The following is a description of a gene set: studied in species Mus musculus Mouse Gene Set: chr8A4, and this is the list of marker genes: Adam34l, Gm38414, Pcm1, Gm5609, Eri1, Gm8436, Zfp148-ps1, Gm45566, Gm2221, Gm35629, Gm26150, Mir6395, Smarce1-ps1, Gm5347 (NCBI Gene Id 384814), Gm34597, Gm5787, Rps12-ps24, Gm26181, Gm16348, Saraf, Gm18414, Gm6180, Gm2080, Erhrt-ps, Prag1, Gm3433, Ccnq-ps4, Triml1, Rpl31-ps23, Adam26b, B930018H19Rik, Gm33968, B430010I23Rik, Gm33831, Sgcz, Gm18644, Trmt9b, Zfp42, Gm9939, Adam34, Gm8423, Gm9951, Gm16193, Gm45349, Gm6284, Slc7a2, Dusp4, Gm34368, 2810404M03Rik, Gm19140, Gm34853 (NCBI Gene Id 102641483), Vps37a, Triml2, Zdhhc2, Gm34419, Gm16204, Gm4889, Gm8268 (predicted gene 8268), Gm39157, Mfhas1, Micu3, Pdgfrl, Frg1, Leprotl1, Dlc1, G630064G18Rik, Ppp1r3b, Fgf20, Cnot7, Adam20, Gm39158, Asah1, Gm7319, Mir7666, Mtus1, Gm5345, Gm6100, Gm29243, AI429214, Gm6213, Gm17766, Gm26632 (predicted gene, 26632), Gm25126, Mir383, Gm19855, Cldn23 (NCBI Gene Id 71908), Gm40493, 1700015I17Rik, 5430403N17Rik, Gm6303, Gm20948, Lonrf1 (NCBI Gene Id 244421), Gm5749, Gm6011, Adam26a, Zfp353-ps, Gm34096, Gm35021, Gm34474, Adam25, Gm8254, Mboat4, Gm16205, Gm16793 (predicted gene, 16793), Adam24, Tnks, Gapdh-ps14, Mtmr7, Gm19410, Gm39164, Gm10683, Gm34533, Gm45488, Gm2033, Adam39, Gm6203, Msr1, Hspd1-ps1, Gm35520, Gm8291, Fgl1, Rbpms, Dctn6, 4933430A20Rik, Gm7082